Given this list of marker genes ARHGAP35, PDLIM3, GEM (GTP binding protein overexpressed in skeletal muscle), ACTN1, CTNND1, PRKD1, PTPN1 (protein tyrosine phosphatase non-receptor type 1), SMARCD1, CDKN1C, PPP3R1, ACTB (actin beta), REXO5 (RNA exonuclease 5), TNFRSF11B, DAPK1, ACP5, STIP1, PPP2R5C, ILK, RPRM, PTPRF, STK17A, DYRK3, KRT18, MAPRE2, ARL4C, TP53, RGS4, RASAL2, MAP4K4, NPC2, ARL6IP5, CYFIP2, CASP4 (caspase 4), SH3BP4, ACTR2, DHRS3, PLCL1, MAPK6, RAB33B, PTPRE, PI4K2A, KIDINS220, DUSP14, PMAIP1, CAPZA1, AXL, RGS5, CARD10, ATP9A, VCL, GBP1 (guanylate binding protein 1, NCBI Gene Id 2633), ITGB5 (integrin subunit beta 5), PIK3CD, TP53I11, TYRO3, TUBA1A, TRIB1, ACTA2, RAB5A, ABLIM1, STK25, CDK14, ACTG2, CAP2, GDI2, DAB2, ARHGAP1, RANGAP1 (Ran GTPase activating protein 1), ADCY7, TK1, TLK1, RAB5C, AKAP12, ACTA1, HSD17B1, FLNC, MAP2K3, STAT1, PAWR, GNB1, ITGA3, THBS1, ADCY9, STK24, TPM2, here is a description of the gene set: from publication Sasson R, Rimon E, Dantes A, Cohen T, Shinder V, Land-Bracha A, Amsterdam A (PMID 15026540) species: Homo sapiens Genes down-regulated in primary granulosa cells in response to forskolin. Gonadotrophins exert a major effect on ovarian development and on the control of fertilization. By stimulating cells with forskolin (FK), it is possible to study which genes are activated by gonadotrophins via the cAMP cascade, and which by alternative pathways. Using RNA isolated from stimulated cells, we found that 59% of the total genes modulated by LH were also modulated by FK, while 69% of the genes modulated exclusively by FSH were also modulated by FK. Gene transcripts involved in steroidogenesis/progesterone production were highly elevated, while 17beta-hydroxysteroid dehydrogenase was down-regulated. This suggests that a decrease in the conversion of androstenedione to testosterone and estrone to estradiol occurs during luteinization. Down-regulation of genes coding for actin cytoskeleton proteins and cytokeratin 18 was observed in response to gonadotrophin and cAMP stimulation. Several of the genes coding for the microtubule network were also modulated, implying that rearrangement of the cytoskeletal proteins permits better coupling between organelles involved in steroidogenesis. A dramatic change in gene transcripts coding for signalling enzymes was observed following LH stimulation. This includes the down-regulation of adenylyl cyclase 7 and 9, elevation of cAMP-dependent phosphodiesterase, and the up-regulation of a negative regulator of G-protein signalling (RGS16) that may negate gonadotrophin signalling via guanine nucleotide binding proteins. Thus luteinized cells, despite increased gene transcripts to LH/chorionic gonadotrophin (CG) receptors, respond inefficiently to gonadotrophin stimulation, due to attenuation of signal transduction in the cAMP cascade at multiple steps. Novel genes involved in the regulation of apoptosis were found for the first time to be up-regulated by gonadotrophin stimulation, including: BAX inhibitor-1, granulysin and apoptosis repressor with caspase recruitment domain (ARC). These proteins may be involved in a unique alternative pathway of ovarian cell death. Such a pathway could temporarily preserve the mitochondria and progesterone production during the initial stages of granulosa cell apoptosis. Human Gene Set: SASSON_RESPONSE_TO_FORSKOLIN_DN